Given this list of marker genes PHOSPHO2, TMEM106A, CCDC51, TMEM229B, USP1, AIFM1, CTDSP1, P2RY14, here is a description of the gene set: Human Gene Set: CAO_BLOOD_FLUZONE_AGE_05_14YO_30DY_DN BACKGROUND: Live attenuated influenza vaccine (LAIV) and trivalent inactivated influenza vaccine (TIV) are effective for prevention of influenza virus infection in children, but the mechanisms associated with protection are not well defined. METHODS: We analyzed the differences in B-cell responses and transcriptional profiles in children aged 6 months to 14 years immunized with these 2 vaccines. RESULTS: LAIV elicited a significant increase in naive, memory, and transitional B cells on day 30 after vaccination, whereas TIV elicited an increased number of plasmablasts on day 7. Antibody titers against the 3 vaccine strains (H1N1, H3N2, and B) were significantly higher in the TIV group and correlated with number of antibody-secreting cells. Both vaccines induced overexpression of interferon (IFN)-signaling genes but with different kinetics. TIV induced expression of IFN genes on day 1 after vaccination in all age groups, and LAIV induced expression of IFN genes on day 7 after vaccination but only in children < 5 years old. IFN-related genes overexpressed in both vaccinated groups correlated with H3N2 antibody titers. CONCLUSIONS: These results suggest that LAIV and TIV induced significantly different B-cell responses in vaccinated children. Early induction of IFN appears to be important for development of antibody responses. from publication Cao RG, Suarez NM, Obermoser G, Lopez SM, Flano E, Mertz SE, Albrecht RA, García-Sastre A, Mejias A, Xu H, Qin H, Blankenship D, Palucka K, Pascual V, Ramilo O (PMID 24495909) species: Homo sapiens Genes down-regulated in blood 30d vs 0d in children (0.5-14y) after exposure to Fluzone, time point 30D. Comment: ~80% of cohort were white, ~50/50 Female:male